Given this list of marker genes MT-TS2, GON7, ACTN4, CLCN5, IRAK1, NOP10, COL4A5, INVS, SLC12A1 (solute carrier family 12 member 1), KCNE5, DKC1, TBC1D8B, SLC41A1 (NCBI Gene Id 254428), OCRL, NAA10, MEFV (MEFV innate immunity regulator, pyrin), ARPC5, SPRY2, CLCN7, FCGR2B, SLC25A11, SEC61A1, ELP1, MTX2, MT-CO2, COQ2, PLEC, YRDC, KIF1B, NUP133, WDR73, MYO1E, NPHS1, FOXC2, ITGA3, ZNFX1, PLCE1, LAGE3, SDHB, CRB2, PAX2, OSGEP, MT-TW, SDHD, ITGB4, RNU7-1, DCDC2, TREX1, DNASE1, FCGR3B, PXK, SDHAF2, FAS, DHX16, MTRR, MT-TV, MECP2, PEX2, FOXP3, SMARCAL1, IL10, NUP85, MT-TH, IL12A, HNF1B, KIRREL1, DNASE2, MPDU1, MDH2, KLRC4, CASP10, WAS, PRKCD, DGKE, TSC2, KIAA0319L, MAGI2, GLA, TPRKB, ANKFY1, ARHGAP24, ANLN, CTLA4, SGPL1, PKHD1, MT-ATP6, G6PC1, COPA, NPHP1, DZIP1L, PTPN22, TLR7, JAZF1, WDR19, INF2, FN1, CD151, MT-ND3, PGM3, MME (NCBI Gene Id 4311), IFNGR1, ITGAM, UMOD, PBX1, CEP290, MT-CO1, PRTN3, ZNF699, ETFB, TP53RK, DAAM2, BLK, NUP160, DNMT3A, IFNG, TULP3, HLA-DPB1, CFHR5, WT1, IL6, UBAC2, NOS1AP, EPAS1, JAG1, KCNQ1, C3, CFH (complement factor H), COL4A3, SDHA, SOX18, MT-TK, BANK1, PDCD1, PIGQ, FASLG, CDKN1C, AVIL (NCBI Gene Id 80056), IRF5, MT-CO3, IGF2, GAPVD1, LMNB2, GATA3, STAT4, IFT140, APOE, ARHGDIA, LAMA5, CFI, TAPBP (NCBI Gene Id 6892), IL23R, SDHC, TLR4, ALMS1, HLA-DPA1, SKIC3, C1QA, CCR1, USP18, IGHG1, XPNPEP3 (X-prolyl aminopeptidase 3), ACSL4, NPHS2, NUP37, LMX1B, MT-ND6, LMNA, NPHP4, H4C3, CD2AP, COQ8B, TRPC6, MT-ND4 (NCBI Gene Id 4538), CSPP1, NUP107, COQ7, HLA-B, LAMB2, TNFSF4, MIF, MT-TQ, SLC37A4, NUP205, ETFA, ERAP1, WDR4, FAH, MT-ND2, MMP1, CLCNKB (chloride voltage-gated channel Kb), MT-TL1, EMP2, MAX, KCNJ1, C4A, NEK8, TMEM67, SCARB2, C4B, BSND, MYOCD, COL4A4, SPP1, JAK1, SOCS1, MT-ND5, PTPRO, CEP83, COL7A1, SLC7A7, VPS33B, FH, RET, MMACHC, TNFAIP3, VPS33A (NCBI Gene Id 65082), VHL, MT-TF, KCNQ1OT1, FCGR2A, MT-ND1, CR2, HLA-DRB1, LACC1, KANK2, UBE2L3, NF1, CD96, NUP93, AMMECR1, CD81, COQ6, ZAP70, NPHP3, TNIP1, PDCD6IP, IL12A-AS1, ADA, ETS1, NIPBL, MUC1, PEX1, DNASE1L3, NARS2, DLST, TMEM127, TRIM8, WIPF1, SLC12A3, APOL1, KIAA0586, REN, LPIN2, ETFDH, here is a description of the gene set: Human Gene Set: HP_ABNORMAL_RENAL_CORTEX_MORPHOLOGY species: Homo sapiens Abnormal renal cortex morphology An abnormality of the cortex of the kidney.